The following is a description of a gene set: Cytosine methylation of mammalian DNA is essential for the proper epigenetic regulation of gene expression and maintenance of genomic integrity. To define the mechanism through which demethylated cells die, and to establish a paradigm for identifying genes regulated by DNA methylation, we have generated mice with a conditional allele for the maintenance DNA methyltransferase gene Dnmt1. Cre-mediated deletion of Dnmt1 causes demethylation of cultured fibroblasts and a uniform p53-dependent cell death. Mutational inactivation of Trp53 partially rescues the demethylated fibroblasts for up to five population doublings in culture. Oligonucleotide microarray analysis showed that up to 10% of genes are aberrantly expressed in demethylated fibroblasts. Our results demonstrate that loss of Dnmt1 causes cell-type-specific changes in gene expression that impinge on several pathways, including expression of imprinted genes, cell-cycle control, growth factor/receptor signal transduction and mobilization of retroelements. Human Gene Set: JACKSON_DNMT1_TARGETS_UP Genes up-regulated in MEF cells (embryonic fibroblast) upon Cre-lox knockout of DNMT1. from publication Jackson-Grusby L, Beard C, Possemato R, Tudor M, Fambrough D, Csankovszki G, Dausman J, Lee P, Wilson C, Lander E, Jaenisch R (PMID 11137995) species: Mus musculus, and this is the list of marker genes: MRE11, TDG, HSPB1, CHEK1, GPR12, XIST, IL10RB, ZFP64, FAM9A, CXCL10, ETV4, MX1, PTGS2 (NCBI Gene Id 5743), KLF4, EIF3A, POLR2A, SLBP, SFRP1, IFIT1B, TRAF3 (NCBI Gene Id 7187), DYNLT2, BIN1, HLA-B, NFE2L2, CDKN1A, EPHA2, ENG, IRF7, TRIM28, REEP5, HMGA1, DAZL, PHLDA1, RELA, IFNGR1, HIF1A, RGS16, EREG, IL1RAP, GTF2H1, CCL2, ISG15, TGOLN2, TSG101, CSK, CRYAB, MAP2K3, AHCY, CTNNB1, TRIM25, CCN1, ECT2, CCNG2, SLPI, SOCS3, JAK2, TRAF4, CDC25A, SIN3A (NCBI Gene Id 25942), IGFBP6, ACKR3, SEMA3C, EIF2AK2, RAD52, FGFR1, IFIT3, PLIN2, GATA2, BAG1, TK1, CEBPZ, PROCR, CYP2E1, RPA2, JUNB, HSPH1, PARP1, THBS2, CSF1, ZFP36, PDGFA